The following is a description of a gene set: Any process that stops, prevents, or reduces the frequency, rate or extent of programmed cell death, cell death resulting from activation of endogenous cellular processes. species: Homo sapiens Human Gene Set: GOBP_NEGATIVE_REGULATION_OF_PROGRAMMED_CELL_DEATH, and this is the list of marker genes: GREM1, XRCC2, HMGA2, PLAUR, NKX3-2, CRIPTO, LCN2, HSPB2, LONRF2, SLC25A31, SOD1, PAX2, TIMP1, MIR21, JUN, TCF7L2, TXNDC5, POU4F1, CAST, MAPK8IP3, PIP, C8orf17, EVI2B, BNIP2, BIRC6, IL4, CBS, MIR485, AURKA, API5, GPX1, FGF20, PIK3R3, GDF5, GRIK2, ATP7A, MNAT1, FZD3 (NCBI Gene Id 7976), FOXO1, SLC25A6, VEGFB, BCL2L2, ZFAND6, UCP2, MIR590, CRLF1, NFATC4, KITLG, MIR20A, MAPK8, CARD14 (NCBI Gene Id 79092), CNTFR, KDM2B, SOCS3, MSH2, SMAD5, XBP1, MUC1 (NCBI Gene Id 4582), OPN3, PIM3, NANOS3, APBB2, PPARD, IRS2, FZD1, FUT1, TPT1, COPS5, HYPK, FATE1, CERKL, WNT5A, AREL1, UBE2B, AIFM2, BTC, USP47 (NCBI Gene Id 55031), ZNF304, PLA2G3, F2R, PAK5, CRYAA, TMEM161A, MGMT (O-6-methylguanine-DNA methyltransferase), BCL2A1, PRAMEF20, BCL2, CREB1, PRKCD, VEGFA, DYRK3, LMNA, GLI3, MET, PRKCI, FMR1-AS1, AZU1, AKR1B1, TAF9, SLC7A5, PIM2, LAPTM5, FANK1, NFKB1, PRAP1, PRKCA, PIK3CG, DKK1, PROP1, MMP9, ARMC10, MIR212, BMP4, BCL2L10, MIR210, FIGNL1, BMI1, NUP62, TRAF2, KAT2B, GRIA4, NRG1, ARL6IP1, CTNNA1, CASP2, FADD, MIR19B1, TM7SF3, RNF157, ITGA5, DNAJA1, BCL6, TMBIM6, MED1, PPEF2, SERPINB13 (NCBI Gene Id 54735), NMNAT1, STUB1, ADGRG1, MIR181C, RELA, ARHGEF2, BAG1, IFIT3, GCLM, HTT, MAPKAP1, PTGS2, PRDM9, TSC22D1, ATAD3A, ACVR1, ALKBH1, PRAMEF22, PRAME, ATF4, BTG2, NR1H4, NNT, MECP2, PIDD1, IGF1, TOPORS, MIR199A1, CTH, RAD21, THBS1, PLAC8, TEX11, ABCC9, HSPA1B, TOX3, ARNT2, SIRT4, ASNS, CORO1A, CFL1, TP53, MIR101-1, CD40LG, NACA, WT1, ZMYND11, POU3F3, KDR, PSEN1, DNAJC5, SLC25A1, AQP1, SHC1, KRT18, NUPR1, CREB3L1, IHH, AGO4, MEF2C, FBXO7, PTPN1, NES, MLST8 (MTOR associated protein, LST8 homolog), PRAMEF14 (PRAME family member 14), PRDX2, PRAMEF15, RTKN2, LRRK2, PRAMEF18, QARS1, EPHA4, UNC5B, GLO1, CCND2, IFI6 (NCBI Gene Id 2537), AR, TYRO3, NPM1, WNT1, ADAMTS20, ACTC1, PLCG2, MIR30B, THAP11, NTRK2, PDK4, ORMDL3, TRIM32 (tripartite motif containing 32), TNFSF18, DLL1, IL31RA, CEACAM5, STAT5A, HIPK2, SIX4, FGG, MT3, DDAH2, MAEA, PTMA, TCIM, MDM2, SIN3A, MAP4K4, DPP8, CCR7, LIMS2, ADORA2A, PALB2, TNIP2, PYCR1, CCND1, ZPR1, IL11, NPY5R, MIF, PAX8, MYCNOS, SYCP2L, MAP3K12, MIR146A, HELLS, DDR2, CXCR2 (C-X-C motif chemokine receptor 2), LTF, RBCK1, BNIP1, LGMN, PRAMEF10, HIP1R, PRR5, ENO1, GPAM, NKX2-5, NDNF, AURKB, PAK4, NTF4, NR2E1, TWIST1, WNT4, NFE2L2, TFAP2D, PARL, HYOU1, FAIM2, PRAMEF2, CNTF, BID, ARG2, PRAMEF27, VDAC1, INTS1, RPS3A, GATA6, LEF1, SLC25A5, ADAM8, DHRS2, TJP1, RB1, BAD (NCBI Gene Id 572), AHI1, GSK3B, GHSR, ANXA5, CCL19, BAK1, SELENOS, XPNPEP1, SQSTM1, NOG (NCBI Gene Id 9241), VSTM2L, PPP5C, ADAR, BIRC2, LHX4, MIR132, CSF1R (colony stimulating factor 1 receptor), BDKRB2, MPO, MAG, BECN1 (NCBI Gene Id 8678), CXCL12, DAB2, ERCC5, HTR2B, BNIP3, NAT8B, PRAMEF4, SRC, TGFBR1, PLK2 (polo like kinase 2), ISL1, SPHK1, SLC9A1, ASCL1, SNCA, HMGN5, PRKCQ, ATF5, PPARGC1A, FKBP8, MARCHF7, IL7R, AARS1, MAPK8IP1, MCL1, FGF10, MICAL1, LACRT, GDNF, MIR126 (NCBI Gene Id 406913), BDNF, NME2, PTK2, JAK2, UFM1, CITED1, AKT1, HRAS, MAP2K4, TMEM109, VPS54, NRBP2, RXFP2, YME1L1, DAPK1 (NCBI Gene Id 1612), GFRAL, FAS, SRSF6, EGFR, MIR495, MIRLET7B, IGF1R, DNAJA3, MIR17HG, ZNF268, UCN, RRN3, SMAD3, MAPK8IP2, CHD8, KLF4, SET, CPEB4, HDAC2, TNFAIP8, FPR2, INS, KRAS, FOXB1, MIR30E, PTTG1IP, NAA35, RAF1, AMBRA1, PRAMEF6, MIR24-1, PF4, ICAM1, NEFL, TGFB3, FAIM, PRAMEF33, DDX3X, NOTCH1, GPRASP3, ING2, CCL21, ADA, PRAMEF19, PTK2B, EDN1, IER3IP1, HDAC3, HEY2, NIBAN2, GPI, EDNRB, IL10, CIAPIN1, PROK2, BARD1, MITF, SOX10, MIR133A1, TNFRSF18, ADPRS, PRKAA1, FGF8, MAGEA3, LRP2, CD28, STAMBP, BFAR, MSX2, BMP7, FGB, PRKCG (NCBI Gene Id 57013), PAK2, IRF7, ANG, HNF1B, LAMTOR5, ANGPT4, RFFL, YAP1, NR4A2, PTGFR, MYC, SGK3, ITGB3, KIT, DOCK8, PLK3, FGF2, IL27RA, AAMDC, MTDH, PSME3, MIEN1, RICTOR, FOXC2, FSTL1, CDK1, TFRC, TMEM215, HSPA9, EYA4, PTRH2, NOS3, ITPRIP, STIL, PCGF2, GNRH1, KDM1A, NCKAP1L, PRAMEF9, PRAMEF7 (NCBI Gene Id 441871), SEMA5A, HSPA5, MTOR, MIR195, RNF144B, AXL, PINK1, PRAMEF26 (NCBI Gene Id 645359), PAGE4, PELI3, PAX7, FFAR4, GSTP1, BIRC5 (NCBI Gene Id 332), SIX1, SLC46A2 (solute carrier family 46 member 2), APOH, RPL10, HMOX1, ANGPTL4, BRAF, YBX3, NUAK2, CAPN3, HIPK3, ARMCX5-GPRASP2, PRDX3, SMG9, CAAP1, PRDX5, PRAMEF8, EN1, MSX1, RNF34, ELL3, FLT4, TMIGD1, MIR22, HPN, PDCD1, TEK, HSF1, PCDHGC5, MIRLET7F1, STXBP1, CCAR2, MIR222, SCRT2, TMF1, HMGB2, PRAMEF25, SIAH2, DAD1, HERPUD1, PPP1R10, ITGB3BP (integrin subunit beta 3 binding protein), URI1, RPS6KA3, LEP, KLHL20, GCG, FXN, SOX8, PIK3R1, HCK, PSMC5, HGF, PRKN, RETREG1, NOL3, SUPV3L1, HSH2D, SYVN1, MIR106B, SYNGAP1, ZNF16, ESR1, RHOA, AGAP2, HNRNPK, HCLS1, SIRT1, BAX, ST3GAL1, SLC1A1, IL1A, FTH1, CSF2, RARB, SLC25A27, SOCS2, MIR29B1, GATA4, DRAXIN, SYCP2, GBA1, SH3RF2, CD2AP, PRAMEF17, NTRK1, TXNDC12, CD38, KHDC3L, SOD2, APIP, CTNNB1, TIGAR, BBS10, GNAI2, LRP6, JAK3, CDSN, NPPC, ARHGAP10, BMP5, RIPK1, HSP90AB1, TMBIM1, OPA1, MIR214, CBLC, LYPD3, PTMS, OSR1, TRIAP1, CX3CL1, NQO1, NOC2L, FOXE3, CLN8, TBX3, HIGD1A, CD44, ITGB1, LILRB1, SOX9, MIR361, IL1B, BAG3, ANP32B, ARF4, SMAD6, ITPKB, MYO18A, RASA1, RRM2B, MFSD8, CIB1, MAEL, DDB1, SNCB, PTPRZ1, SPRY2, HSPG2, CDC73, SNAI1, OXR1, MIR17, CSNK2A2, CTTN, SLC35F6, IL6ST (interleukin 6 cytokine family signal transducer), ATOH1, GOLPH3, CIDEA, ANGPT1, BARHL1, MAPK7, MAP2K5, ITGA6, RHBDD1, HTRA2, EN2, ATOX1, IL19, POR, IL6, SH3RF1, PDPN, KIF14, GATA2, SNX6, PRAMEF11, MYDGF, TP73, VHL, STK40, ITCH, MERTK, GATA3, HAND2, FGF4, NRP1, PRNP, CSNK2A1, GRN, PLK1, PRAMEF1, LIG4, LGALS3, HSPB6, NOTCH2, SCX, ZNF830, ROCK1, TNFRSF10D, PSMG2, FZD9, PRKCH, FOXP1, PPIA, FGFR2, PRELID1, UBE2Z, EEF2K, CCN1, MUTYH, STAT5B, NPC1, AKR1A1, EPO, SERPINB9, IDO1, WNT7A, SON, RNF31, C8orf44-SGK3, ENSG00000274276, HAX1, PRKAA2, CCR5, PRAMEF12, NUGGC, EYA3, EYA1, TERT, BCL3, NAIP, WNK3, DDRGK1, ACAA2, TAF9B, MYOCD, TREM2, CBX4, MDM4, TENT5B, PPIF, TNF, TLE1, PEA15, ALOX12, SHH, NKX2-6, PDPK1, DUSP1, PIM1, BCL2L1, TMBIM4, MIR142, YWHAZ, VTCN1, ACKR3, PARK7, WNT16, BCL2L12 (BCL2 like 12), CX3CR1, IL2, PRLR, EIF2AK2, CDH5 (NCBI Gene Id 1003), AIPL1, SERPINB2, FCMR, IKBKG, BIRC7, EGR3, IL7, PEPD, POU3F4, GRINA, CRYAB, PHIP, CAV1, RAMP2, TFAP2B, RORC, CDKN1B, TAX1BP1, GHITM, BRCA1, CLEC5A, CREB3, NTSR1, MAGEA4, PLXND1, MDK, HIGD2A, MIR223, ARAF, MIR182, LTK, NOD2, CFDP1, HSP90B1, TBX1, NEUROD1, BIRC8, PRAMEF13, LHX3, IL2RB, SCG2, COL2A1 (collagen type II alpha 1 chain), PDCD10, ASIC2 (acid sensing ion channel subunit 2), NR4A3, PELI1, GPX4, SMO, TMEM14A, GCLC, NONO, ARHGDIA, CBL, IL13, PRKDC, CD74, CXCR3, SERPINE1 (NCBI Gene Id 5054), UNG, SEMA4D, MIR15B, PDX1, ANXA1, ERBB4 (erb-b2 receptor tyrosine kinase 4), ATG5, CDKN2D, HSPD1, TFAP2A, MIR200B, HSPB1, CLU, CD27, GAS6, PROC, DIPK2A, TNFAIP3, AVP, CCL2, KRIT1, FHL2 (NCBI Gene Id 2274), WFS1, BAG4, PIK3CA, SFRP1, SLC25A4, TSC22D3, BIRC3, PKHD1, SLC7A11, CAT, AVEN, RGL2, FGA, MAZ, FMN2, NME5, PRKCZ, ADNP, RPS6KB1, ASAH2, TRAP1, MIR138-1, PPT1, ANXA4, GBE1, PCDHGC4, MRE11 (MRE11 homolog, double strand break repair nuclease), PSMD10, ADORA1, CITED2, GATA1, AMIGO2, RB1CC1, CEACAM6, SNAI2, ERFE, SIRT5, XIAP, MTNR1B, IVNS1ABP, DDIAS, CHL1, MALT1, CCL5 (C-C motif chemokine ligand 5), SFRP2, TNFRSF6B, COMP, KIFAP3, BOK, DSTYK, MECOM, BCL10, HDAC1, ATAD5, BAG5, GHRL, ITGAV, RAG1, PRAMEF5, PTCRA, PA2G4, IER3, PIK3CB, HIF1A, STRADB, SLC39A10, NAA15, RPS6KA1, MPV17L, NTF3, PCDHGC3, ABL1, MIR221, BAG6, AATF, CFLAR, TSLP, RARA, RACK1, SLC40A1, DNMT1, BNIP3L, HSPA1A, DNAJC3, BCL11B, CLCF1, CLN3, SC5D (NCBI Gene Id 6309), MIR92A1, EFNA1, MAP2K1, CASP8, ID1, NGF, FCER1G, BABAM2, DPP9, ANKLE2, MNT, NAA38, NAA16, ZC3H12A, CAMK1D, PDE3A, ZNF385A, CHST11, FOXC1, CEBPB, KANK2, DLX1, MIR19A, GRK5, ERBB3, FLNA (NCBI Gene Id 8272), ERBB2, EYA2, PTH, PHB2, DSG2, PPARA, PIAS1, DFFA (DNA fragmentation factor subunit alpha), MIR145, SEMA3E, FYN (NCBI Gene Id 2534), ACLY